Given this list of marker genes PIEZO2, SNRPE, IDI1, TMBIM1, RTP4, POLR1B, DAXX, ARL14, MYO19, SLC25A1, OVOL1, SYTL5, PANK3, RSAD1, DHCR24, NKX1-1, OASL, SRA1, RUFY3, HOOK1, VAT1, WDR17, EML5, POLR1C, PLSCR1, MIRLET7E, PIEZO1, HSPD1, UTP4, PIK3C2G, CCL3, CNOT6L, GOT1, SETMAR, SMARCB1, RPN2, UCHL1, EIF5A2, TAF9, EIF4E, PFDN2, SYNCRIP, GIT1, PUSL1, SRM, CCT6A, ECE2, VAPA, NDUFC2, POU5F1, FNBP1, GTF2F1, THOP1, NETO2, MIR16-1, PEX14, EGR3, VEGFB, FOXRED2, ASB5, GEMIN6, UBE3D, GALNT2, ST6GALNAC4, FOXO6, APOBEC4, GPR52, PSPH, TOMM22, INSM1, PSMD7, URGCP, COQ6, ERCC8, ZBTB2, MAFG, GPR61, ZMYND19, DCTD (NCBI Gene Id 1635), MAB21L1, KLHL11, KATNA1, ART5, GLT1D1, TMEM183A, TBRG4, SCIN, IMPDH2, DNAJC2, GNG4, TENT5C, SUPT3H, CIAO2A, GOLGA5, MCRS1, MRPL11, TMEM70, IPO4, SLC9B2, MIR484, VPS8, IFRD2, SLC25A39, ETS2, ACY1, UBE2U, PICK1, AIMP1, PIP5K1C, HOMER1, POMC (proopiomelanocortin), SESN2, DNAJA2, MIR155, CCNO, CRLS1, ID1, PLK3, STEAP1 (STEAP family member 1), PRR15, H1-6 (NCBI Gene Id 3010), VEGFA, ANKRD55, IL15RA, STK19, IL12B, CHPF, KCTD15, HSPA4, AACS, NANOS1, TMEM200B, NOL9, TOR1AIP2, RAB6B, FAM43A, SLC35B2, KARS1, SLC52A1, GUK1, OTULIN, ATP1B3, DDX21, MIR17HG, SLC39A4, EIF3A, SIX4, CCDC9, CEBPZ, CCDC116, REM2 (NCBI Gene Id 50847), KLHDC4, KDR, KIF17, NR1H4, LIPT1, SLC5A6, PPP1R16A, SLC2A6, GABRA3, here is a description of the gene set: Genes down-regulated in CD4 T conv: control versus over-expression of IKZF4 and FOXP3. The transcription factor FoxP3 partakes dominantly in the specification and function of FoxP3+ CD4+ T regulatory cells (Tregs), but is neither strictly necessary nor sufficient to determine the characteristic Treg transcriptional signature. Computational network inference and experimental testing assessed the contribution of several other transcription factors (TFs). Enforced expression of Helios or Xbp1 elicited specific signatures, but Eos, Irf4, Satb1, Lef1 and Gata1 elicited exactly the same outcome, synergizing with FoxP3 to activate most of the Treg signature, including key TFs, and enhancing FoxP3 occupancy at its genomic targets. Conversely, the Treg signature was robust to inactivation of any single cofactor. A redundant genetic switch thus locks-in the Treg phenotype, a model which accounts for several aspects of Treg physiology, differentiation and stability. from publication Fu W, Ergun A, Lu T, Hill JA, Haxhinasto S, Fassett MS, Gazit R, Adoro S, Glimcher L, Chan S, Kastner P, Rossi D, Collins JJ, Mathis D, Benoist C (PMID 22961053) studied in species Homo sapiens Human Gene Set: GSE40274_CTRL_VS_FOXP3_AND_EOS_TRANSDUCED_ACTIVATED_CD4_TCELL_DN